The following is a description of a gene set: Human Gene Set: REACTOME_LEUKOTRIENE_RECEPTORS Leukotriene receptors studied in species Homo sapiens, and this is the list of marker genes: CYSLTR1, LTB4R, CYSLTR2, LTB4R2, GPR17